The following is a description of a gene set: species: Mus musculus Mouse Gene Set: REACTOME_GLUCAGON_SIGNALING_IN_METABOLIC_REGULATION Glucagon signaling in metabolic regulation, and this is the list of marker genes: Prkar1b, Prkar1a, Gcg, Gcgr, Prkaca, Prkacb